Given this list of marker genes PTK2, CXCL17, MAPK1, AKIRIN1, TRPV4, IL34, MDK, CCL2, C3AR1, MAPK3, CSF1R, RARRES2, SLAMF1 (NCBI Gene Id 6504), PTPRJ, C5AR1, CCL5, TNFSF18, MSTN, CSF1, THBS1, CMKLR1, here is a description of the gene set: species: Homo sapiens Human Gene Set: GOBP_POSITIVE_REGULATION_OF_MACROPHAGE_CHEMOTAXIS Any process that increases the rate, frequency or extent of macrophage chemotaxis. Macrophage chemotaxis is the movement of a macrophage in response to an external stimulus.